The following is a description of a gene set: studied in species Mus musculus Any process that stops, prevents or reduces the frequency, rate or extent of T-helper 17 type immune response. Mouse Gene Set: GOBP_NEGATIVE_REGULATION_OF_T_HELPER_17_TYPE_IMMUNE_RESPONSE, and this is the list of marker genes: Il2, Cd69, Ascl2, Zbtb7b, Tnfsf18, Rc3h1, Tbx21, Lgals1, Smad7, Il27ra, Il4, Zc3h12a, Rc3h2, Foxp3, Pf4, Loxl3